The following is a description of a gene set: species: Mus musculus Increase in size of antral follicles due to cell proliferation and/or growth of the antral cavity. Mouse Gene Set: GOBP_ANTRAL_OVARIAN_FOLLICLE_GROWTH, and this is the list of marker genes: Esr1, Gpr149, Scaper, Nppc, Ereg, Ptx3, Tnfaip6, Foxo3, Ptger4, Gas2, Npr2, Bmpr1b, Zp3